The following is a description of a gene set: Human Gene Set: CREB_Q2_01 species: Homo sapiens Genes having at least one occurrence of the motif NNTKACGTCANNNS in the regions spanning 4 kb centered on their transcription starting sites. This matches the CREB1 transcription factor binding site V$CREB_Q2_01 (v7.4 TRANSFAC)., and this is the list of marker genes: ILVBL, GPRC5C, TRIM39, GLYR1, HOXC10, DDX28, PPP2R2A, KCTD8, KLHL12, GLB1L, CMSS1, SNAP25, STK16, DUSP1, UBE4A, PNMA3, TMEM39A, PITX2, PDXDC1, PINX1, PSKH1, EVX1, THADA, XRCC6, MAP1LC3A, MBNL2, GRP, IRF2BPL, DDX51, SREBF2, SPAG9 (NCBI Gene Id 9043), RIPOR1, GEM, ASPHD1, ATG5, ZCRB1, CACNB2 (calcium voltage-gated channel auxiliary subunit beta 2), RECQL5 (RecQ like helicase 5), AREG, SYNGR3, PPHLN1, SENP2 (SUMO specific peptidase 2), TRA2B, VPS37A, BTAF1, JUN, RELB, ESM1, ZNF687, SLC25A3, TACR1, ID1, LGR5, MAFF, UBE2B, CENPE, TBC1D32, CYLD, DDX19A, SIK1, PNRC1, CREM, PEG3, NPPC (NCBI Gene Id 4880), CNOT7, NUBPL, NFKBID, SYNCRIP (synaptotagmin binding cytoplasmic RNA interacting protein), YTHDC2, PFAS, RPRD1A (NCBI Gene Id 55197), SLC25A25, KYAT1, AHI1, JOSD1, JUND, ZFYVE27, FGF6, CLCN3, DEPDC4, PLK4, SHISA7, MRRF, NOL4, SDHB (NCBI Gene Id 96200), APPBP2, MLF2, TPM4, LDHA, CDS1, CYSTM1, NOC4L, FAM131A, UBE2H, C5orf46, FOXD3, MARCHF6, GNL1, AKIRIN1, CLDN7, CLSTN3, CLCN4, CTC1 (CST telomere replication complex component 1), RAB24, FAM167A, ENSA, DNTTIP1, RAI1, IKBKB, TGIF2, ABHD16A, CBX8, SRP54 (signal recognition particle 54), ZIM2 (NCBI Gene Id 23619), CALD1, TSC22D3, TAFA1, H4C5, SRRM4, SLC18A2, PRR3, DHX36, NCDN, DNAJC27, SARNP, PNMA6A (NCBI Gene Id 84968), SNAPC5, SCG2, PRELID1, PPARGC1A (PPARG coactivator 1 alpha), PITPNC1, HHIP, PTPRU, VPS37B, SLC6A5, ZNF367, ZNF593, TAF2, RBP5, AFF4, DCTN1, MCAM, ITFG2, CDC42, SPRED2, FBXL2, ORMDL2, RPS29, HDAC6, RNF44, RPS6KA3, WNT10A, FAM174A, PAK1, FOSB, BIN1, GTF2A1, NEUROD6, RNF166 (ring finger protein 166), PDLIM3, ADAP1, ZNF516-DT, TAOK2, RUNDC3A, ARG2, MMGT1, SPI1, KCNA5, ATL2, HS3ST3A1 (heparan sulfate-glucosamine 3-sulfotransferase 3A1), WFDC3, SIDT2, LTBP1, EGR1, TSC22D2, HS3ST2, CHPF, PCSK1, PDE7A, MXD1, RCAN1, CLDN6, CD2AP, SYT11, CHGB, ZFY, ABR, THOC1, CEP15, DAAM2, OSR1, ING3, IRX4, TRAF4, NSD3, TRIB1, ADNP, TIPRL, NPTX1, CDC42EP4, PPM1A, FLT1, NR4A2, MRGPRF, GPM6B, RBM18, CCND2, PPP1R15A, TMEM59L, SAP30BP, ORMDL3, ZFAND2B, BRAF, TGFB3, NF1, EPHA2, C11orf87, ADNP2, ZFAND5, ERF, TPT1, SULT4A1, DUS2, GPBP1, PAFAH1B1, UBA6